The following is a description of a gene set: Posttranscriptional addition of a methyl group to either a nucleotide or 2'-O ribose in a polyribonucleotide. Usually uses S-adenosylmethionine as a cofactor. Human Gene Set: GOBP_RNA_METHYLATION species: Homo sapiens, and this is the list of marker genes: METTL8, METTL3, MEPCE, HENMT1, BUD23 (BUD23 rRNA methyltransferase and ribosome maturation factor), METTL14, FDXACB1, TRMT2B, LARP7, TYW3, LCMT2, SNRPD3, TFB1M, SPOUT1, METTL15P1, RBM15, RBM15B, TRMT6, TARBP1, RAMACL (NCBI Gene Id 353267), TRMO, SNRPF, SNRPG, RAMAC, TGS1, TRMT1, TRMT9B, NSUN2, METTL6, MRM2, METTL2B, NSUN5P1, SNRPB, METTL16, ZCCHC4, FTSJ1, NOP2, MRM1, METTL15, FBLL1, WDR6, THUMPD2, METTL5, DIMT1, NSUN5, TRMT61A, TRMT44, RNMT, SNRPD1, NSUN5P2, TRMT1L, METTL25B, ALKBH8, NSUN4, TRMT112, TRDMT1, TRMT5, MTO1, TRMT10C, TRMT10B, NSUN6, NSUN3, FBL, SNRPE, EMG1, TRMT61B, DALRD3, TRMT12, WDR4, HSD17B10, METTL1, TRMT10A, MRM3, TFB2M, TRMT13 (NCBI Gene Id 54618), THUMPD3, AKT1, THADA, BCDIN3D, METTL2A, FTSJ3, GTPBP3, SNRPD2 (small nuclear ribonucleoprotein D2 polypeptide), NSUN7